The following is a description of a gene set: Mouse Gene Set: chr16C3 studied in species Mus musculus, and this is the list of marker genes: Gm5676, Gm30790 (predicted gene, 30790), Gm18550, 4930500H12Rik, Gm33255, Adamts5, Krtap13-23, Gm23406, Krtap13-1, Krtap6-7, Gm34396, 1700066C05Rik, D16Ertd472e, Rpl31-ps4, Krtap6-2, Tmprss15, Son, 4930403O18Rik, Ifnar2, Krtap8-1, 4930534H18Rik, Krtap15-1, Gm10791, Gm32865, Gm6032, Gm49227, 2810407A14Rik, A630036G19Rik, Mirlet7c-1, Krtap6-1, Gm36001, Gm32624, Olig1, Mir99ahg, Gm25896, Krtap27-1, Gm24695, Krtap26-1, Krtap20-22, Robo2, Gm25699, Gm22808, Map3k7cl, Gm7860, Gm25547, Gm7559, Gm49558, Gm25715, Gm15555, Gm18549, Il10rb, 1700063K16Rik, Mis18a, 4930570E03Rik, Epcip, C130023A14Rik, 4930553J12Rik, Gm26307, Krtap19-5, Dnajc28, Gm32461, 7120432I05Rik, Krtap6-3, Hunk, Grik1, Gm6278, Atp5pf, Cldn8, Gm17844, Gm46546, Gm18918, 1110008E08Rik, Cldn17, Gm9843, Gm5675, Gm30162, B130034C11Rik, Krtap20-20, Cxadr, Lipi, Adamts1, N6amt1, Cct8, Krtap6-6, 4930578N18Rik, Tiam1, Gm25038, 8030451O07Rik, Paxbp1, 9530003O04Rik, Tmem50b, Gm18021, Gm36169, Krtap22-2, Hspa13, Krtap16-3, 4930478L05Rik, Cyyr1, Gm7501, Gm23355, Mir691, E330011O21Rik, Jam2, Chodl, Gm7856, 2310079G19Rik, Ifnar1, Krtap13, Krtap20-2, Mrap, Samsn1, Fkbp1a-ps3, Gm15553, 1700041M19Rik, Krtap20-24, Robo1, Rbm11, Mrpl39, 4931420L22Rik, Gm25916, Gm31258, Krtap6-5, Gm41480, Gm7667, Gm41492, Gm19291, Krtap13-22, Btg3, Gm38477, H3f3a-ps2, Gm22797, Gm26153, Mir125b-2, D16Ertd519e, 4930567J20Rik, Krtap7-1, Eva1c, Gm18825, Gm7307, Gm2805, Ltn1 (listerin E3 ubiquitin protein ligase 1), Olig2, Gart, Gm32357, 9430053O09Rik, Gm23994, Krtap11-1, Krtap13-21, Usp16, Bach1, Urb1, Gm18168, A930006K02Rik, Gm23655, Rpl21-ps5, Krtap13-24, Usp25, A730009L09Rik, Gm2349, Gm22268, Gm15554, Krtap19-9b, Sod1, Mir6367, Krtap19-4 (keratin associated protein 19-4), Gabpa, Gm15964, Ncam2, Mir155hg, krtap20-23, Gm30726, Nrip1, 4930551I23Rik, Ifngr2, Krtap21-1, Gm7831, Krtap20-21, Gm23083, Krtap19-9a, Krtap19-3, Krtap13-20, Gm22163, 9430092D12Rik, 4930404I05Rik, 4930420G21Rik, Gm29823, Scaf4, Mir99a, App, 1700007H22Rik, Gm36363, Krtap19-2, 4930556C24Rik, Krtap24-1, Krtap20-1, Mir155, Krtap19-1, Pgk1-ps1, Rps19-ps12, Gm2477, 4930553E22Rik, Rwdd2b, Gm7295, Cfap298, Gm2541, Gm24891, Synj1, Gm19867 (predicted gene, 19867), Gm41481, Gm46562, Krtap14